The following is a description of a gene set: Any process that modulates the frequency, rate or extent of cell activation, the change in the morphology or behavior of a cell resulting from exposure to an activating factor such as a cellular or soluble ligand. studied in species Mus musculus Mouse Gene Set: GOBP_REGULATION_OF_CELL_ACTIVATION, and this is the list of marker genes: Ascl2, Ephb4, Lmo4, BC037156, Pawr, Il15, Tyro3, Skint1, Bpi, Nfatc2, Cd19, Cd27, Tespa1, Sdc4, Dusp3 (dual specificity phosphatase 3 (vaccinia virus phosphatase VH1-related)), Bloc1s3, H2-Eb2, Pglyrp1, Il7, Rabgef1, Pcid2, Hspa4, Pglyrp2, Ceacam1, Bcl10, Pf4, Shh, Rps3, Hrg, Mpl, Timd5, Trp53bp1, Cd84, Pglyrp4, Fanca, Zfp36l1, Tnfsf18, Tec, Il33, Vav1, Cd226, Il1rl1, Cd9, Cebpa, Nfkbid, Hspb1, Itgal, Foxp3, Dnaja3, Mmrn1, Il1b, Lgals3, Spi1, Sphk1, Gp1ba, Capn3, Arg1, H2-DMb2, Sh2d1b2, Pik3r6 (NCBI Gene Id 432574), Cdkn1a, H2-Ob, Havcr1, Sash3, Il2ra, Vtcn1, Btnl2, Svep1, Slamf7, Shb, Tarm1, Cd47, Cd22, Tnfsf11, Adora2a, Dhps, Gal, Ctla4, Cyp26b1, Lrfn5, Smarcc2, Vsig4, Ahr, Ldlr, Lbp (lipopolysaccharide binding protein), Smarcd2, Sox11, Sphk2, Gnrh1, Zfp608, Tgfbr2, Ighm, Prkar1a, Ripk3, Sit1, Cd86 (NCBI Gene Id 677252), Cd1d2, Klrk1, Tyk2, Emilin1, Prkg1, Ccr7, Selenok, Tnfsf13, Arid2, Dicer1, Lilra5, Kat2a, Nlrp3, Lilrb4b (leukocyte immunoglobulin-like receptor, subfamily B, member 4B), Il3, Znhit1, Tnf, Dusp22, Efnb2, Flna, Cd59b, Raet1d, Il6st, Prkcz, Themis2, Rc3h2, Clnk, Abl1, Ctsg, Thbs1 (thrombospondin 1), Lef1, Vcam1, Fgr, Supt6, Rps6ka1, Tnfrsf4, Hsp90aa1, Ywhag, Rag1, Cbfb, Smo, Flt3l, Mcub, Il1a, Smad7, Pms2, Traf6, Mdk, Ankle1, Gimap5, Pten, Rara, Fgfr1, Prkca, Kitl, Btk, Bad, Xrcc6, Axl, Ctsc, Tyrobp, C1qtnf1, Btla, Ephb6, Scgb1a1, Nr5a2, Sox4, Kmt5c, Prkaa1, Tigit, Zfp683, Il27ra, Clec4d, Cx3cl1, Prdm1, Braf, Aplf, Tnfrsf13b, Ptpn2, Ndfip1, Ufl1, Pkn1, Csf1r, Ambra1, Twsg1, Tnfrsf1b, Mad2l2, Cd4, Cd209a, Rnf41, Fancd2, H2-Aa, Cyrib, Tspan32, Src, Plscr1, Spta1, Il2rg, Hamp, Zp3, Tnfaip3, Rif1, Coro1a, Il36b, Clcf1, Slamf1, Pla2g5, Smarcd3, Prnp, Nod2, Ccdc88b, Tox, Runx1, Ada, Lilrb4a, Calhm2, Clptm1, Cygb, Hsph1, Rhbdd3, Ephb2, Klhl25, Dlg1, Lst1, Itpkb, Nr4a3, Mfsd2b, Sox13, Tmem131l, Kat5, Atp11c, Ulbp1, H2-DMa, Mapk8ip1, Pla2g2f, Mmp14, Cd200, H2-M3, Cgas (NCBI Gene Id 214763), Kcnn4, Cd6, Rasgrp1, Rhoh, Tff2, Slc4a1, Card11, Dock8, Bcl2, Gpnmb, Acta2, Ptprj (protein tyrosine phosphatase receptor type J), B2m, Ticam1, Timd6, Cd40, Kmt5b, Glmn, Laptm5, Abl2, Il27, Tnfsf13b, Gjd4, Icos, Cd160, Ubash3b, Ptprc, Opa1, Aif1 (allograft inflammatory factor 1), Trex1, Arid1a, Pdcd1lg2, Shld2, Hps1, Gimap3, Lyn, Bank1, Cst7, Lyst, Efnb3, Mmp8, Clec7a, Cd3e, Lat, Dapl1 (death associated protein-like 1), Socs6, Ifnb1, Wnt5a, Smarcd1, Ap3b1, Hlx, Sh2b3 (NCBI Gene Id 16923), Pdgfa, Cd1d1, Pde5a, Cela2a, Tmx1, Chrnb2, Cd80, Cd300lb, Cd209e, Shpk, Adam8 (a disintegrin and metallopeptidase domain 8), Nedd9, Marchf7, Pag1 (NCBI Gene Id 94212), Jund, Siglecg, Cd69, Cdkn2a, Mir181b-1, Cd300a, Zap70, Bmi1, Rhoa, Ido1, Slc7a2 (NCBI Gene Id 11988), Cd55, Adk, Drosha, Slc7a1 (NCBI Gene Id 264068), Akirin2, Ptpn6, Adgrf5, Fadd, Ccn2, Tbc1d10c, Pla2g2d, H2-Ea, Peli1, Vav3, Fer, Pck1, Blm, Ptpn22, Dgat1, Nsd2, Tafa3, Il12b, Il16, Zc3h12d, Ccl21a, Fgl1, Cd300lf, Dtx1, Adrm1, Mettl3 (methyltransferase 3, N6-adenosine-methyltransferase complex catalytic subunit), Cd44, Sos2, Sox12, Lax1, Rasal3, Slc4a2, Zfp36l2, Cd37, Mlh1, Milr1, Loxl3, Zc3h12a, Il15ra, Nfkbiz (NCBI Gene Id 80859), Pbrm1, Lrrc32, Ep300, Mir326, Rassf5, Wnt3a, Tcf7, Zfp335, Cyld, Tlr6, Paxip1, Brd7 (NCBI Gene Id 27017), Gper1, Ccr6, Btn2a2, Rc3h1, Malt1, Sart1, Plek (pleckstrin), Cd5, Foxo3, Clec4g, Ppp2r3c, Cd81, Tbx21, Exosc6, Thy1, Dpp4, Myd88, Tlr9, Cd244a, F11r, Hmgb3, Shld3, Pycard, Pagr1a, Egr3, Prkcd, H2-Ab1, Igfbp2, Pdgfrb, Mzb1, Epo, Lgals8, Cd274, Pla2g10, Nr1d1, Sftpd, Tfrc, Icosl (NCBI Gene Id 50723), Vnn1 (NCBI Gene Id 22361), Il23a, Smarcc1, Pdgfra, Pja2, Inpp5d, Il20rb, Tnfrsf13c (NCBI Gene Id 72049), Lgals1 (lectin, galactose binding, soluble 1), Apoe, Nkap, Lgals9 (lectin, galactose binding, soluble 9), Zbtb7b, Il7r, Actl6b (NCBI Gene Id 83766), Emilin2, Csk, Gpr137b, Il6, Fbxo38, Slfn1, Sh3rf1, Prkcq, Clec12a, Vsir, Atad5, Nfam1, Lck, Cblb, Flt3, Crlf2, Il1rl2, Ccl2, Tgfb1, H2-Oa, Sos1, Il18, Tnfrsf21, Irs2, Smarcb1, Exosc3, Ptpre, Enpp3, Nrarp, Mill1, Brd2, Cd320, Cnr2, Ctla2a, Ddrgk1, Prlr, Bcl6, Mef2c, Ptpn11, Mfhas1, Ap3d1, Ccr2, Cftr, Rian, Nck1, H2-Eb1, Hes1, Fn1, Mif, Myb, Snca, Gas6, Lag3, Hspd1, Bmp4, Dcaf15, Il10, H2-DMb1, Brd4, Tnfaip8l2, Parp3, Fundc2, Xbp1, Il21, Serpine2, Tnfsf14, Pglyrp3, Slc46a2, Cebpb, Muc5b, Erbb2, Sirpa, Ildr2, Il4i1, Tnfsf4, Htr2a, Klhl22, Pnp, Zmiz1, Il2, Gp1bb, Gata3, Cd209d, Zfp609, Clec2i, Vps33b (vacuolar protein sorting 33B), Fcho1, Bst1, Plscr2, Jak3, Pla2g4a, H2-T23, Slc39a10, Actb, Cav1, Mertk, Cd24a, Gp5, Sox15, Wnt10b, Itch, Sh3kbp1, Atm, Fgl2, Ikzf3, Cd28, Syk, Ttbk1, Myo18a, Sfrp1, Efnb1, Fcgr2b, Ighd, Rac2, Klrd1, Irgm1, Hmgb1, Pibf1 (progesterone immunomodulatory binding factor 1), Stap1, Slc15a4, Cnr1, Smarce1, Hfe, Bid, Il12a, Spn (NCBI Gene Id 20737), Ripor2, Timd2, Socs5, Nck2, Crtam, Tcf3, Il4ra, Nckap1l, Kcnk18, Adamts18 (NCBI Gene Id 208936), Ddr2 (NCBI Gene Id 98699), Ccl20, Grn, Ihh, Pdcd1, Cd276, Zfp35, Anxa1, Zc3h8, Duxbl1, Arg2, Foxj1, Lep, Tnip2, Stat5b, Dppa1, Ifng (NCBI Gene Id 15978), Jak2, Cd83, Prdx2, Plpp6, Zbtb46, Ctnnb1, Mir181b-2, Lmo1, Shld1, Smarca2, Slamf8, Il4, Gp9, Tlr4, Ccl19, Carmil2, Mad1l1, Rag2, Smarca4, Pdpn, Il5, Cd46, Tac1, Tacr1, Mir150, Pear1, Syt11, Scrib, Casp3, Gpam, Cd74 (CD74 antigen (invariant polypeptide of major histocompatibility complex, class II antigen-associated)), Gclc, Alox12, Cd38, Actl6a (NCBI Gene Id 99742), Xcl1, Kars1, Zeb1, Gli3, Irf1, Tirap, Cd59a, Stat6, Msh2, Il12rb1, Nr1h3, Stat5a, Tnfrsf9, Prelid1, Pla2g2a, Havcr2, Il13, Rorc, Gpr183, Tsc2 (TSC complex subunit 2, NCBI Gene Id 22084), Selp, Bloc1s6, Fam76b, Lrrk2, Pparg, Fbxo7, Nectin2, Cd209c, Foxn1, Phf10, Flot2, Pdgfb, Id2, Fas, Dlg5, Dusp10, Tslp, Socs1, Igf2, Cd55b, Fgf10, Runx3, Ccl5, Cd40lg, Ripk2, Zbtb1, Rora, Tnfsf9, Hmces, Gnaq, Samsn1, Fcer1g, Tnfrsf14, Igf1, Trem2, Prkdc, Mir301, Il6ra, Ppp3ca, Ager